Given this list of marker genes RB1, TSKU, TP53INP1, MIR9-1, MIR98, PDCD4, MIR27B, here is a description of the gene set: Human Gene Set: GOBP_NEGATIVE_REGULATION_OF_MYOFIBROBLAST_DIFFERENTIATION Any process that stops, prevents or reduces the frequency, rate or extent of myofibroblast differentiation. species: Homo sapiens